Given this list of marker genes XKR8, JADE1, CSK, BEX3, DPF3, QSOX1, DOCK1, ANKH, LOXL3, PTPN9, KLF7, SLK, MARCHF8, RPL23AP32, CDC23, TMEM204, ABR, TBP, EFL1, DNAJC12, ZNF675, BMPR2, TPM4, ANXA11, CAMTA2, HAL, COPS7A, RPS24, GTF2E1, HECA, NLRX1, TOB1, MARCHF2, CSTF1, SH3BP5, TXN2, JTB, TOR3A, ERGIC2, MAP3K3 (mitogen-activated protein kinase kinase kinase 3), AGTPBP1, DBR1, VWF, STX18, FBXL14, B3GNT2, ZC3H13, WDR47, KAT2B, INPP5D, IDH3B, GDPD3, GCM2 (glial cells missing transcription factor 2), STAT6, SCAF8, BCORL1, VWA1, SLAMF7, CELF2, MYO1C, UBASH3A, MME, STRADA, DMWD, MED12, TINAGL1, PATZ1, FAM193A, HOXA2, TMEM62, MPST, VIPAS39, TMEM184B, REN, PDCD4 (NCBI Gene Id 27250), PROX1, LPXN, PARP2, WDR45B, SHLD2, GLUD2, CALCOCO1, CD48, SNRNP40, PREP, VPS39, MAGOH2P, NDEL1 (nudE neurodevelopment protein 1 like 1), LIMS2, MBD3, ITPR1, NADSYN1, HAVCR1, WFDC1, LSM1, NETO2, TOPBP1, DDX31, FASTKD5, TPTE, PTPRCAP, MPRIP, EBI3, SARAF, ARSB, NRN1, SH3YL1 (SH3 and SYLF domain containing 1), ATP10D (ATPase phospholipid transporting 10D (putative)), CDKN2AIP, NPY5R, B3GNTL1, SERPINE2, TBCB, CIDEB, CDK5RAP1, KRT3, TUBA3D, RAB31, HGH1, TLK2, EXTL2, AIMP1, TGFBI, TAF4B, CTDSP2, MLF2, SEC11A, PRDM8, CHRNB1, BMI1, GNPDA1, OGFRL1 (NCBI Gene Id 79627), PIGG, C1orf54, TMEM260, SLC25A12, LAMP1, CCND3 (NCBI Gene Id 896), GUSBP14, LMTK2, UFC1, KIR2DS2, ACTR10, LRP8, PLPP3, STK39, S100A14, LARS2, SRSF6, MMP14, OR7E14P, UBQLN4, IL36G, CD99, GSN-AS1, HK1, DENND1C, RNF44, CRTC3, LPGAT1, CCDC6, GCKR, SH2B3, OLAH, ARL5A, PRNP, CZIB, DOLPP1, TAS2R14, IMPA1, CLDN14, NDUFS2 (NCBI Gene Id 4720), GLB1, IL22, ABCC3, APOF, MAP3K7, MRPS10, PPP1R3D, OR3A2 (NCBI Gene Id 4995), HIGD2A, MYOG, CD68, ARHGEF40 (NCBI Gene Id 55701), SYNDIG1, CMPK1, CARM1, PCOLCE2, KCTD2, PTPN7 (protein tyrosine phosphatase non-receptor type 7), RP2, MILR1, KIN, WFDC2, MDFI, DUSP10, AGPAT2, ICE1, here is a description of the gene set: studied in species Homo sapiens Genes up-regulated in HEK293 cells expressing mutant NOD2: untreated versus muramyl dipeptide for 6h. from publication Billmann-Born S, Till A, Arlt A, Lipinski S, Sina C, Latiano A, Annese V, Häsler R, Kerick M, Manke T, Seegert D, Hanidu A, Schäfer H, van Heel D, Li J, Schreiber S, Rosenstiel P (PMID 21335489) NOD2 is an intracellular receptor for the bacterial cell wall component muramyl dipeptide (MDP) and variants of NOD2 are associated with chronic inflammatory diseases of barrier organs e.g. Crohn disease, asthma and atopic eczema. It is known that activation of NOD2 induces a variety of inflammatory and antibacterial factors. The exact transcriptomal signatures that define the cellular programs downstream of NOD2 activation and the influence of the Crohn-associated variant L1007fsinsC are yet to be defined. To describe the MDP-induced activation program, we analyzed the transcriptomal reactions of isogenic HEK293 cells expressing NOD2wt or NOD2L1007fsinsC to stimulation with MDP. Importantly, a clear loss-of-function could be observed in the cells carrying the Crohn-associated variant L1007fsinsC, while the NOD2wt cells showed differential regulation of growth factors, chemokines and several antagonists of NF-κB, e.g. TNFAIP3 (A20) and IER3. Human Gene Set: GSE22611_UNSTIM_VS_6H_MDP_STIM_MUTANT_NOD2_TRANSDUCED_HEK293T_CELL_UP